Given this list of marker genes Ocln, Paqr8, Casp6, Hgf, Krtap19-1 (keratin associated protein 19-1), Mier3 (NCBI Gene Id 218613), Jak2, Ppil4 (peptidylprolyl isomerase (cyclophilin)-like 4), Snx19, Sp3, Lyset, Mybl1, Fosl1, Ano3, Clk2, Lrrc7, Ikzf5, Slc43a3, Or5b95, Gcfc2, Dlg2, Prxl2c, Rhot1, Nufip1, Ndufaf4, Armcx4, Nufip2, Lrrc57, Fst, Zbtb34, Zfp933, Ccnl1, Aqp4, Tmem26, Cfap52, Chml, Cd300lf, Zfp677, Tead1, Snai2, Cavin2, Daglb, Cdk4, Slc18a2 (solute carrier family 18 (vesicular monoamine), member 2), Fem1c, Ro60, Ngf, Smpx, Mfap2, Numbl, Jdp2, Tshz1, Med14, Faap24 (Fanconi anemia core complex associated protein 24), Akirin1, Etl4, Meox2, Alas1, Rab6b, Rnf145, Sall3, Neto1, Yipf4, Mycbp2, Irf2, Lrrtm2, Colec12, Rnf214, Col6a3, Ccar1, Cacna2d1, Snx7, Rrm2b, Cnot6l, Fgl2, Irak1bp1, Piezo1, Col6a5, Acsl1, Mrpl49, Dspp, Plekha3, Zfp512b, Csmd2, Cd40, Fgd4, Arf6, Pde8b, Atp2a2 (ATPase, Ca++ transporting, cardiac muscle, slow twitch 2), Sox5, Ints8, Pdcd2l, Tbr1, Tjp1, Camsap2, Qpct, Cenpe, Ppip5k2, Rnft1, Dbf4, Hbs1l, Lzic, Cyp26b1, Notch1, Atp1b4 (NCBI Gene Id 67821), Sucla2, Gabpa (NCBI Gene Id 14390), Fhod3, Tmem117, Ankrd12, Ntrk2, Adamts1, Sema3c, Fam13c (family with sequence similarity 13, member C), Ltbp4, Nlgn1, Cd207, Smurf2, Entpd1, Ccdc39, Cox6a2, Atp8b1, Rac3, Spcs3, Sertad2, Celf2, Fmnl1, Ica1l, Casp12, Ufm1, Snx1, Crispld1, Hectd2, Pcdh15, Bend3, Trhde, Zfp24, Cadm2, Bub1, Ctdspl2, Grm8, Elovl5 (NCBI Gene Id 68801), Gata6, Szrd1, Zfp267, Jak1, Zbtb44, Stk38l, Col13a1, Kif1b, Msl2, Lmx1a, Dusp1, Yy1, Id2, Serpinc1, Pof1b, Lcorl, Aldh18a1, Cldn1, Wnt3, Sh3bp5, Pax3 (NCBI Gene Id 18505), Jade1 (NCBI Gene Id 99826), Glce, Rap1b, Phip, Rilpl2, Ubtfl1, Zmynd11, Nup188, Stip1 (stress-induced phosphoprotein 1), Zhx2, Ctbp2, Maml2, Nek7 (NIMA (never in mitosis gene a)-related expressed kinase 7), Fam91a1, Mctp1, Crim1, Fbxo38 (F-box protein 38), Slc5a7, Tmem47, Gja6, Neurod1, Tmem132b, Gm527, Elavl3, Cdca7, Cstf3, here is a description of the gene set: Genes predicted to be targets of miRBase v22 microRNA mmu_miR_568 in miRDB v6.0 with MirTarget v4 prediction scores > 80 (high confidence targets). studied in species Mus musculus Mouse Gene Set: MIR_568 from publication Chen Y, Wang X (PMID 31504780)